The following is a description of a gene set: Comparison of two Chlamydia-specific CD4 T cells that are dependent on iNOS to terminate Chlamydia replication in epithelial cells to two Chlamydia-specific CD4 T cells that are iNOS-independent: Chlamydia trachomatis urogenital serovars replicate predominately in epithelial cells lining the reproductive tract. This tissue tropism poses a unique challenge for the host immune system and vaccine development. Studies utilizing the Chlamydia muridarum mouse model have shown that CD4 T cells are critical and sufficient to clear primary genital tract infections. In vitro studies have shown that CD4 T cells terminate the infection in epithelial cells by up regulating epithelial iNOS transcription and nitric oxide production via IFN-gamma and T cell-epithelial cell interactions mediated by LFA-1-ICAM-1. This mechanism however is not critical as iNOS-deficient mice clear infections normally, and IFN-gamma deficient mice clear 99.9% of the infection with near normal kinetics. We recently showed that a subset of Chlamydia-specific CD4 T cell clones were able to terminate replication in epithelial cells using a mechanism that was independent of iNOS and IFN-gamma. That mechanism did not require physical lysis of infected cells, but instead required T cell degranulation. In this study we advanced that work using gene expression microarrays to compare CD4 T cell clones that are able to terminate epithelial replication via an iNOS-independent mechanism to iNOS-dependent CD4 T cell clones. Micro array experiments showed that Plac8 was differentially expressed by the T cell clones having the iNOS-independent mechanism. Plac8-deficient mice had significantly delayed clearance of C. muridarum genital tract infections, and that the large majority of Plac8-deficient mice treated with the iNOS-inhibitor N-monomethyl-L-arginine (MLA) were unable to resolve a C. muridarum genital tract infection over 8 weeks. These results demonstrate that there are two independent and redundant T cell mechanisms for clearing C. muridarum genital tract infections; one mechanism dependent on iNOS, the other mechanism dependent on Plac8. While T cells subsets have been defined by cytokine profiles, there are important subdivisions by effector functions, in this case CD4Plac8. studied in species Homo sapiens Genes up-regulated in T cell activation mechanism that was NOS2 dependent versus NOS2 independent activation. from publication Johnson RM, Kerr MS, Slaven JE (PMID 22238459) Human Gene Set: GSE32128_INOS_DEPENDENT_VS_INOS_INDEPENDENT_ACTIVATED_TCELL_UP, and this is the list of marker genes: RPRD1A, CYP2S1 (cytochrome P450 family 2 subfamily S member 1), ARID1A, COL1A1, ZNF518B, GOLGA4, CSTB, SRRD, ARL8B, PRKACA, CXCR4, AKAP8L, PCTP, SNX17, TNFSF9, DNM1, DHRS3 (NCBI Gene Id 9249), MTMR10, NOL7, ESPN, TMEM45A, PPP4R1, SERPINB2, HSPA1B (heat shock protein family A (Hsp70) member 1B), JARID2, PIP5K1B, CLCN1, ZNF326, CKAP5, CCDC6 (NCBI Gene Id 8030), CST11, IDH1, STAT5A, PI4K2A, MIF4GD, SLC2A8, BAP1, HBS1L, PIM3, RBMS1, TNNC2, UBE2Z, ARIH2, CIAPIN1, ANXA5, CAB39, THAP11, VAT1, PKP2, APOBEC3B, HDAC7, HOXB13, TGFB1, NCOA4, MMD, WNT2, KCTD20, RIPOR1, HMGA1, DNMT3A, HYOU1, SPRYD3, NFYC, SDR42E1, TIPARP, DUSP11, TACC2, UBE2N, WBP2, LSR, SLC11A2, CASP3, PRKCSH, KMT5A, SMIM12, BCAT2, DVL2, SNX20, DNAJB1, MMP1, OVGP1, SRR, ARFIP2, AP3M1, CDYL, MAPK6, GSTM3 (glutathione S-transferase mu 3), ZNF622, PLCD1, TBC1D13, SOCS6, SRCAP, DHRS1, DKK1, MARCKSL1, ADAM2, STAT5B, CFD, IFFO2, GPCPD1, URM1 (NCBI Gene Id 81605), CXCL3, INTS6L, KAZALD1, BMPR1A, TGIF2, RDM1, TPCN1, GAA, APC2, COPRS, MCRIP1, OTUD7B, TRAF5, MYO7A, HAVCR1, GNA13, SERTAD3, RNF19A, CBL, DOCK5, NAAA, HLA-B, DERL1, FAM131B, EIF4A2, COPA, TMEM268, RFNG (RFNG O-fucosylpeptide 3-beta-N-acetylglucosaminyltransferase), ENPP3, CYTIP, NEUROG3, AURKA (NCBI Gene Id 8465), CKAP4, LGALS7, PLPP2, HGF, JUND, SRP14, GPS2, ADSS1, CDKN1C, LRRC59, AAR2, STK40, FZD1, CCL20, THOC6 (THO complex subunit 6), TBC1D23, RRAD, P2RX6, SDC4, RNF214, NDRG4, MCCC1, MAP3K7, MAPRE2, RND3, SMO, SERPINE2, ZMYND11, SNX4, GPRASP1, ZNF790, RHOBTB2, DSP, FAM241B, SEC23A, GRIN3B, PKIG, PRUNE1, AHI1, EPHA5 (NCBI Gene Id 7304), EVX2, GRIK5, RIOK3, RAB1A, PPP3CB, BUD13, FAM53C (NCBI Gene Id 51307), MFGE8, DNPEP, RALGPS2, CYB5R3, MYRF, STAM2, ADIPOR2, CGGBP1, ABCD4, ANXA2, OBP2B, DDX19B, AKR1B1, RCOR1, HRH1 (NCBI Gene Id 3269), ITPRID2, GALNT11, SEL1L, GABRA2, TTC1